The following is a description of a gene set: A complex that catalyzes the transfer of an acetyl group to the N-terminal residue of a protein acceptor molecule. studied in species Homo sapiens Human Gene Set: GOCC_N_TERMINAL_PROTEIN_ACETYLTRANSFERASE_COMPLEX, and this is the list of marker genes: NAA20, NAA11, NAA35, NAA15, NAA30, NAA50, NAA38, NAA10, NAA16, NAA25